Given this list of marker genes RUNX3, MRPS6, FBXO42, TRAFD1, NIBAN3, LHPP, NOP10, YIF1B, PTPN12, MRPL42, HIVEP2, BATF3, PUS10, ADGRL2, EIF2B3, TRIM28, MRPS12, PHRF1, DCTN3, RBM19, NUDCD3, MED17, ARRB1, HADHB, HSPE1, CLUH, DOP1B, USP47, PCBP1, SSX2IP, SLC29A1, AHNAK, MAGOHB, SUB1, VGLL4, ORAI1, RUVBL1, RAN, AIFM1, PSMB2, LYAR, ACTN1, HMOX2, SLC9A5, NLE1, CDK1 (NCBI Gene Id 983, cyclin dependent kinase 1), PSMC2, HRAS, KATNA1, DDX55, BOLA1, ABCF1, RCC2, MAF, CRIP1, AGRN, GNPNAT1, PRPF18 (NCBI Gene Id 8559), VDAC2, CD3D, IQGAP2, PDCD1, PDSS2, NUP210, TXN, ACAT1, TIMM10, IRF7, GTF3C5, YBX1, CABP4, DHX29, EEF1E1, ITGB1, SPINT1, COX6A1, PSMB4, RPL7L1, MLKL, EXOG, COX6B1, KIT, PML, CTSV, POGLUT2, RIOX2, IFRD2, SLAMF9, ZNF428, EIF4A3, MAN2C1, ORC1, CDK10 (cyclin dependent kinase 10), PELP1, UQCR10, CENPV, TBC1D10B, HTRA2, NOC3L, UMPS, RABGGTB, TMEM238, SUPT6H, PDCD11, EIF4G1, SUMO3, H2AZ1, GFI1, IL6R, MRPL21, GLE1, KIAA0232, ENTPD1, TFRC, TBC1D16, MFSD2A, PFDN2, DDX24, FADD, ADPRM, TMEM97, PPIA, WDR83, TYMS, PSMG3, CCN6, CD5L, KDM6B, SPC24, GPN3, RRAS2, SFI1 (SFI1 centrin binding protein), NOP9, AFTPH, CYRIA, FBLIM1, MAD2L1, ATP5MG, CDYL2, WWP1, SDE2, TREX1, NADK, INPP5B, STOML2, EIF2B1, SLC19A1, ORMDL3, EIF6, MANF, MRPS22, G6PD, TGFB3, HASPIN, PSMA4, TUBA1B, ECE1, PTTG1, PLAC8, SEC13, MTHFD1, H2AJ, PSMD8, MED9, FAM53A, ATP5PF, ESYT1, TMED10, RABL6, GCSH, MPHOSPH6, B3GNT2, DCTPP1, PREPL, FAM241A, EIF5A, AHCYL2, MRPL1, SEC11A, SPCS2, NFKBIB, EZH2, EEF1AKMT1, ETFB, NAPSA, DUSP12, KPNA3 (NCBI Gene Id 3839), PSMB6, PROS1, MT1E (metallothionein 1E), MRPL40, TIMM8B, TRAPPC2B, SHMT1, SUV39H1, PTPRJ, VCL, SKA1, CCDC181, MPC2, here is a description of the gene set: Human Gene Set: GSE41867_LCMV_ARMSTRONG_VS_CLONE13_DAY6_EFFECTOR_CD8_TCELL_UP Genes up-regulated in CD8 T effector cells at day 6 of chronic infection: LCMV-Armstrong versus LCMV-Clone 13. species: Homo sapiens from publication Doering TA, Crawford A, Angelosanto JM, Paley MA, Ziegler CG, Wherry EJ (PMID 23159438) During acute viral infections, naïve CD8+ T cells differentiate into effector CD8+ T cells and, after viral control, into memory CD8+ T cells. Memory CD8+ T cells are highly functional, proliferate rapidly upon reinfection and persist long-term without antigen. In contrast, during chronic infections, CD8+ T cells become “exhausted” and have poor effector function, express multiple inhibitory receptors, possess low proliferative capacity, and cannot persist without antigen. To compare the development of functional memory T cells with poorly functional exhausted T cells, we generated longitudinal transcriptional profiles for each.